The following is a description of a gene set: Human Gene Set: BOYLAN_MULTIPLE_MYELOMA_D_UP from publication Boylan KL, Gosse MA, Staggs SE, Janz S, Grindle S, Kansas GS, Van Ness BG (PMID 17483317) studied in species Mus musculus Multiple myeloma is an incurable plasma cell malignancy for which existing animal models are limited. We have previously shown that the targeted expression of the transgenes c-Myc and Bcl-X(L) in murine plasma cells produces malignancy that displays features of human myeloma, such as localization of tumor cells to the bone marrow and lytic bone lesions. We have isolated and characterized in vitro cultures and adoptive transfers of tumors from Bcl-xl/Myc transgenic mice. Tumors have a plasmablastic morphology and variable expression of CD138, CD45, CD38, and CD19. Spectral karyotyping analysis of metaphase chromosomes from primary tumor cell cultures shows that the Bcl-xl/Myc tumors contain a variety of chromosomal abnormalities, including trisomies, translocations, and deletions. The most frequently aberrant chromosomes are 12 and 16. Three sites for recurring translocations were also identified on chromosomes 4D, 12F, and 16C. Gene expression profiling was used to identify differences in gene expression between tumor cells and normal plasma cells (NPC) and to cluster the tumors into two groups (tumor groups C and D), with distinct gene expression profiles. Four hundred and ninety-five genes were significantly different between both tumor groups and NPCs, whereas genes were uniquely different from NPCs in tumor group C and genes were uniquely different from NPCs in tumor group D. Similar to human myeloma, the cyclin D genes are differentially dysregulated in the mouse tumor groups. These data suggest the Bcl-xl/Myc tumors are similar to a subset of plasmablastic human myelomas and provide insight into the specific genes and pathways underlying the human disease. Genes up-regulated in group D of tumors arising from overexpression of BCL2L1 and MYC in plasma cells., and this is the list of marker genes: PPM1A, RRM2B, FSTL1, OBSCN, SUSD3, ADGRL2, BACH1, HSPB1, GGCT, CHST7, LMNB2, AARS1, SPATS2, POLR1A, TGS1 (trimethylguanosine synthase 1), SLC35F2, TLN2, CPM, PIK3IP1, PRODH, PRSS23 (serine protease 23), PCP4, USP15, ZNF839, AFAP1, ADAT1, EIF5, BCAP29, NIPA1, SLC49A4, CINP, KLF9, NRF1, ADM, YDJC, AGTPBP1, L3MBTL3, SNHG12, SETD4, NAPSA, RWDD3, ASPH, ZNF507, CLYBL, EQTN, BLVRB, DGLUCY, FUT11, NSMF, TRMT61A, ARHGAP29, EBF3, ARL4A, CPN1, COX6A2, SPIRE1, SLC15A3, AKT3, GPHN, GART, FABP5, CCND1, ITGA6, CLBA1, DYNC2I2, SLC47A1 (solute carrier family 47 member 1), ISL1, NEFH, TIMM9, CLMN, CHD4, FAM221A, COA8, NFIX, CLEC2D, MYC, PDZD2, BAG5, PLK2, LRIG3, SERTAD4, SH3BGRL2, RAPGEF6, MXRA8, GSTO1, CCR7, DDIT3, DHCR24, KIAA1671, IRF2BP2, PTPDC1